Given this list of marker genes IL2 (NCBI Gene Id 3558), IL1A, IL13, IL1B, HLA-DRB1, CSF3, CXCL1, IFNG, PDGFA, CSF2, TNF, CD4, IL10, HLA-DRA, CXCL2, IL3, IL6, IL15, IL5, IL12B, CSF1, IL11, IFNB1, IL4, TGFB1, IL7, here is a description of the gene set: Human Gene Set: WP_CYTOKINES_AND_INFLAMMATORY_RESPONSE Cytokines and inflammatory response studied in species Homo sapiens